Given this list of marker genes APC, TRIP11, FANCD2, GDF5, DYNC2H1, ZIC3, TRIO, MMP9, VPS35L, LMBR1, GLI3, EXT1, PDE4D, NOG, IHH, EXT2, PITX1, OBSL1, SHOX (NCBI Gene Id 6473), FGFR3, DHODH (dihydroorotate dehydrogenase (quinone)), SALL4, FKBP10, NALCN (NCBI Gene Id 93074), SHH, AFF4, TPM2, GSC, NIPBL, MMP13, BRCA1, CHST3, ALG12, PALB2, DONSON, BMPR1B, TBX3, SCARF2, CUL7, RBM10, RAD51C, FGFR2 (NCBI Gene Id 2263), BRCA2, MAFB, RECQL4, RBM8A, HOXD13, UBE2T, DHCR7, EXOC6B, FANCF, FANCA, RPS19, FANCL, PLXND1, MACROH2A1, TGFB1 (transforming growth factor beta 1), RAD51, XRCC2, PIGT (phosphatidylinositol glycan anchor biosynthesis class T), FANCM, ATR, FANCC, ROR2, COL2A1, JAG1, FANCG, REV3L, B2M, ESCO2, PRKAR1A, RFWD3, BHLHA9, RPL26, RIPK4 (receptor interacting serine/threonine kinase 4), FANCI, DVL1, MAD2L2, TNNT3, CHN1, NPR2, FANCB, LRP4, WNT7A, CHD7, FGFR1, CCDC8, FGF10, SF3B4, CCNQ, FANCE (FA complementation group E), IFT81, FLNB, SLX4, BRIP1, TBX5, ERCC4, EIF4A3, TNNI2, MYH3, here is a description of the gene set: Human Gene Set: HP_APLASIA_HYPOPLASIA_INVOLVING_FOREARM_BONES Absence (due to failure to form) or underdevelopment of one or more forearm bones. Aplasia/hypoplasia involving forearm bones species: Homo sapiens